Given this list of marker genes EEF2, GAB1, KRT8, NDN, GAR1, FHOD3, IGFBP3, LAS1L, HSD3B7, RAB31 (RAB31, member RAS oncogene family), ATF4, MAOA, MYADM, LCN2, NEUROD6, ARG1, C2orf80, SERPINE2, RELL1, BGN, LY6G6D, KRT86, RAP1GDS1, COL17A1, CRTAM, SLC44A4, C1QA, CHRNA7, CASQ1, HDLBP, GPLD1 (glycosylphosphatidylinositol specific phospholipase D1), SNORC, BEX1, GRIK1, FAM107B, ADRB1, CP, AQP4, SLU7 (NCBI Gene Id 10569), MID1, ADGRE1, PRCC (NCBI Gene Id 5546), TNNT2, ALOX15, OSER1, IL5, CISH, CES1, SGK1, TPMT, RPL15, LYL1, PHLDA2, CCNA1 (cyclin A1), IFNAR2, GNG3, SRXN1, TEAD2, SERPINB2, SAG (NCBI Gene Id 6295), MYL1, PLA2G7, SERPINB5, KDM5A (lysine demethylase 5A), ABHD8, INPP4A, ADAM15, ARFIP2, CLCN1, COL18A1, PPT2, CYP2F1, GSTO1, TFCP2L1, COL4A3, CCNF, SCEL, TSN, ACSL1, SEBOX, GDNF, VTN, GSTM5, SH3GL3, ACTC1, CLIC4, HOXB9, DNAAF11, TMBIM1 (NCBI Gene Id 64114), EIF4B (NCBI Gene Id 55378), ICAM1, LTF, EHHADH, SLC2A4, UBAP1, TNNT3, MYH4, H1-1, PLXNA1, ABCC8, TERT, SIAH2, RBL2, SEZ6, FRZB, PTGIR, ETS2, TBX3, NDUFA1, PGAM2, ONECUT1 (one cut homeobox 1), MYH1, CA6, TACSTD2, NDUFV1, TOLLIP, PTPRJ, LIPC, CRHR2, GPN2, TGIF2, UNC119B, PLAT, KRT4, PTGDR2, CUZD1, WNT7B, FAM3C, C1orf43, ARIH2, BARX1, PHEX, VAMP4, KRT6A, FOXC1, HRC (NCBI Gene Id 3270), AGPAT1, ERN2, IGF2, FOXA1, EXT2, TWIST1, SPMAP2, ACTA1, GHRL, REEP1, PKP2, PIP5K1A, KCND2, GGT1, SOX2, ST8SIA3, TNF, CCNB1IP1, GOLGA4, NFATC2, GSTA3, NTN1, PRR5, AOC3, NR1D1, DNAJC21, SNW1, MAGEL2, ETF1, TMEM50B, MEF2B, IRF6, MELTF, CHRNB1, TGFB2, NFE2, MED1, KRT15, SLC35G6, TUBB4A, PIGR, CLP1, TUSC2, POLE3, SFTPC, MEG3, PPL, MPRIP, PRSS12, EPHA8, PPP2R1B, PFDN5, TPST1, SLC66A2, PTTG1IP, ADH1C, KIF1B, ATP7A, JUND, IGF2BP2, CLDN1, HBEGF, CCDC152, ANXA3, here is a description of the gene set: from publication Navarro MN, Goebel J, Feijoo-Carnero C, Morrice N, Cantrell DA (PMID 21399638) The present study reports an unbiased analysis of the cytotoxic T cell serine-threonine phosphoproteome using high resolution mass spectrometry. Approximately 2,000 phosphorylations were identified in CTLs of which approximately 450 were controlled by TCR signaling. A significantly overrepresented group of molecules identified in the phosphoproteomic screen were transcription activators, co-repressors and chromatin regulators. A focus on the chromatin regulators revealed that CTLs have high expression of the histone deacetylase HDAC7 but continually phosphorylate and export this transcriptional repressor from the nucleus. HDAC7 dephosphorylation results in its nuclear accumulation and suppressed expression of genes encoding key cytokines, cytokine receptors and adhesion molecules that determine CTL function. The screening of the CTL phosphoproteome thus reveals intrinsic pathways of serine-threonine phosphorylation that target chromatin regulators in CTLs and determine the CTL functional program. We used Affymetrix microarray analysis to explore the molecular basis for the role of HDAC7 in CTLs and the impact of GFP-HDAC7 phosphorylation deficient mutant expression on the CTL transcriptional profile. species: Homo sapiens Genes up-regulated in wildtype cytotoxic T lymphocytes versus those overexpressing phosphorylation deficient form of HDAC7. Human Gene Set: GSE27092_WT_VS_HDAC7_PHOSPHO_DEFICIENT_CD8_TCELL_UP